The following is a description of a gene set: species: Homo sapiens Human Gene Set: GOMF_PHOSPHOFRUCTOKINASE_ACTIVITY Catalysis of the transfer of a phosphate group, usually from ATP, to a phosphofructose substrate molecule., and this is the list of marker genes: PFKFB4, PFKFB1, PFKM, PFKFB2, PFKFB3, PFKP, PFKL